The following is a description of a gene set: species: Homo sapiens Human Gene Set: HP_MYOCLONIC_SPASMS Myoclonic spasms, and this is the list of marker genes: INPP5E (inositol polyphosphate-5-phosphatase E), TXN2, SMARCB1, MT-ATP6, PIK3CA, AKT1, SMARCE1, GNAS, MOCS1, TRAF7, BAP1, BRAT1, PDGFB, STX16, NF2, MOCS2, SUFU, SLC1A4, SMO, TERT